The following is a description of a gene set: species: Homo sapiens Human Gene Set: GOMF_PARACELLULAR_TIGHT_JUNCTION_CHANNEL_ACTIVITY Enables size- and charge-selective transport of solutes through a tight junction barrier paracellularly, across the epithelium., and this is the list of marker genes: CLDN17, CLDN10, CLDN19, CLDN15, CLDN16, CLDN2